Given this list of marker genes ATP2C1, ATP13A2, ATP2B3, ATP7B, ATP8B1, ATP2B4 (NCBI Gene Id 54594), ATP2A3, ATP10D, CAMK2A, ATP2B2, ATP9B, ATP11B, ATP1A3, ATP1A2, ATP2A1, ATP2B1, PLN, ATP4A, ATP8A1, CAMK2D, ATP9A, ATP13A1, CAMK2B, ATP10B, FXYD7, ATP13A4, FXYD2, ATP2A2, ATP1B3, SLN, ATP8A2, ATP8B2 (ATPase phospholipid transporting 8B2), ATP8B3 (NCBI Gene Id 57203), FXYD3, ATP1B1, ATP4B, CALM1, ATP11A, ATP1A4, ATP1B2, ATP11C, FXYD6, FXYD4, ATP10A, CAMK2G, ATP1A1, ATP12A, ATP8B4, FXYD1, PDZD11, ATP13A5, ATP2C2, ATP7A, CUTC, SRI, here is a description of the gene set: The P-type ATPases (E1-E2 ATPases) are a large group of evolutionarily related ion pumps that are found in bacteria, archaea and eukaryotes. They are referred to as P-type ATPases because they catalyze auto-phosphorylation of a key conserved aspartate residue within the pump. They all appear to interconvert between at least two different conformations, E1 and E2. Most members of this transporter family pump a large variety of cations (Kuhlbrandt W, 2004). Reactome Pathway: Ion transport by P-type ATPases species: Homo sapiens part of: Ion channel transport